The following is a description of a gene set: Human Gene Set: HP_AUTOIMMUNE_ANTIBODY_POSITIVITY Autoimmune antibody positivity species: Homo sapiens The presence of an antibody in the blood circulation that is directed against the organism's own cells or tissues., and this is the list of marker genes: FAS, ACTB, SLC18A3 (NCBI Gene Id 6572), IL12A, MMP2, EIF2AK4 (eukaryotic translation initiation factor 2 alpha kinase 4), COL4A5, SYT2, IGHG1, RIPK1, DNASE1, PLCG2, FOXP3, IRF5 (interferon regulatory factor 5), PRKCD, POMP, JAK2 (NCBI Gene Id 3717), BLK, CARD10, AGRN, SLC25A1, TNFSF15, CD247, ELANE, GALE, HNF4A, PAX4, CHRND, CEL, IL10, LACC1, GFI1, TSHR, STAT4, NARS2, JAZF1, DUT (NCBI Gene Id 1854), DOCK11, CALR, SBDS, IL12RB1, PRTN3, ARPC1B, CTNNB1, IL2RA, ANKRD55, PLEC, TREX1, ALG14, CCN6, ACP5, GLIS3, SRP19, DEF6 (DEF6 guanine nucleotide exchange factor), SLC22A4, IL2RB, CASP10, TERC, NFKBIL1, RHD, PLCG1, CSF2RA, TSHB, IFNGR1, FADD, STAT1, DNAJC3, CYBC1, SPP1, CHAT, TNFSF4, CRYAB, GCK, STX16, CLPB, PLAGL1, FOXE1, HLA-DPB1, PREPL, POU2AF1, CIITA, RASGRP1, PDCD1, MS4A1, SCN4A, ZFP57, SOCS1, FASLG, FCGR2A, FCGR2C, TLR7, CD244, GRIN2A, RHCE, COPA, UBE2L3, LYN, SPIB, TNFAIP3, KLF11, NFKB2, PTPN2, TAP2 (NCBI Gene Id 92048), FCGR3B, TNPO3 (NCBI Gene Id 404679), RFXANK, CTLA4, MYO9A, HLA-DPA1, CMPK2, NLRP1, C4A, TET2, INS, IRAK1, TLR8, ETS1, THRB, TCIRG1, KCNJ11, PTPN22, NEUROD1, SERPINA1, PXK, HLA-B, UBA1, BACH2, HLA-DQB1 (NCBI Gene Id 7924), FCGR2B, TRHR, SHARPIN, DOK7, TERT, C1QB, STING1, VAMP1, C1QC, ABCC8, CHRNE, IFNG, CR2, HNF1A, MECP2, APPL1, LBR, MPL, SNAP25, MPV17, PRF1, COLQ, HLA-DRB1, SLC5A7, COL4A6, HYMAI, ITGAM (NCBI Gene Id 3684), PDX1, RAPSN, ADA, KIAA0319L, TNIP1, CSF2RB, COL13A1, MMEL1, MUSK, GNAS, CHRNB1, TRMT10A, PGM3, ITCH, SAT1, STAT3, AIRE, BANK1, C4B, ICOSLG, GNE, ADA2, RHAG (NCBI Gene Id 6005), DNASE1L3, SLC7A7, CHRNA1